The following is a description of a gene set: studied in species Homo sapiens Human Gene Set: chr13q33, and this is the list of marker genes: MIR2681, METTL21C, BIVM, RPL35P9, TPP2, DAOA-AS1, MYO16-AS2, EFNB2, RNA5SP39, LINC00399, MIR1267, HMGB3P7, ENSG00000287734, LIG4, ABHD13, RPL7P45, MYO16, NALCN, LINC00343, RNY1P2, MIR4705, FGF14-IT1, METTL21EP, POGLUT2, BIVM-ERCC5, LINC01067, LINC01309, ARGLU1, ERCC5, RNU1-24P, TNFSF13B, RNA5SP38, NALF1, LINC00460, LINC00370, ARGLU1-DT, ATP6V1G1P7, MYO16-AS1 (MYO16 antisense RNA 1), RPL39P29, DAOA, CCDC168, FGF14-AS1, LINC00555, HCFC2P1, SNORD31B, FGF14, ATP5MC1P5, FGF14-AS2, ENSG00000308108, LIPT1P1, PPIAP24, TEX30, ENSG00000276957, SLC10A2, NALF1-IT1, ITGBL1